The following is a description of a gene set: The 'de novo' formation of a microtubule, mediated by the microtubule organizing center. Mouse Gene Set: GOBP_MICROTUBULE_NUCLEATION_BY_MICROTUBULE_ORGANIZING_CENTER species: Mus musculus, and this is the list of marker genes: Tppp, Mzt1, Cep192, Nin, Cenpj